Given this list of marker genes Nrp1, Notch1, Ccl28, Dmd, Cass4, Pdgfb, Grem1, Clasp1, Myf5, Dapk3, Mink1, Dusp3, Bcl6, Bcar1, Cdh13, Ppm1f, Onecut2, Plpp3, Cd36, Spry4, Col8a1, Map4k4, Bcl2, Nid1, Ecm2, Lgals1, Wdpcp, Rac2, Disc1, Enpp2, Gsk3b, Col16a1, Pkhd1, Npnt, Src, Col26a1, Rhoa, Egfl6, Unc13d, Ccl21f, Mdk, Braf, Foxf1, Ccl21b (C-C motif chemokine ligand 21B (leucine)), Nf1, Arpc2, Plg, Adam15, Spp1, Acvrl1, Smoc1, Dmp1, Plekha2, Cripto, Cdk6, Has2, Edil3, Iqgap1, Rac3, Crkl, Rhod, Smoc2, Dmtn, Gpm6b, Fzd4, Dlc1, Mmp14, Onecut1, Triobp, Ptk2b, Ptn, Ddr1, Sdc4, Macf1, Camsap3, Col1a1 (collagen, type I, alpha 1), Rcc2, Muc21, Flna, Smad3, Lims1, Kank1, Epha3, Jup, Olfm4, Dnm2, Lrp1 (low density lipoprotein receptor-related protein 1), Dock5, Clasp2, Rin2 (Ras and Rab interactor 2), Coro1c, Dag1, Nexmif, Vtn, Fn1, Coro2b, Angpt2, St6gal1, Prkce, Wnt1, Dicer1, Csf1, Tbcd, Cask, Rras, Ptprz1, Ilk, Nedd9, Serpine1, Slk, Sec1, Fut1, Thy1, Itgb3 (NCBI Gene Id 268495), Jak2, Emp2, Tek, C1qbp, Ccdc80, Itgb1bp1, Ptprj, Tsc1, Rac1, Hsd17b12, Meltf, Crk, Skap1, Mmp12, Ajap1, Alox15, Spock2, Ccl21a, Itga3, Arhgap6, Rreb1, Ap1ar, Tacstd2, S100a10, Calr, Ccl21d, P4hb, Pkp2, Fbln2, Itga5, Jag1, Gcnt2, Spock1, Rock1, Rell2, Emilin1, Fermt2, Efemp2 (epidermal growth factor-containing fibulin-like extracellular matrix protein 2), Fbln1, Fermt1, Pcsk5, Abi3bp, Ndnf, Efna5, Pten, Ptk2 (NCBI Gene Id 14083), Cib1, Thbs1, Dusp22, L1cam, Sema3e, Hoxa7, Phldb2, Fam107a, Epha1, Actg1, Cdkn2a, Pdpn, Ptpn1, Wnt4, Poldip2, Dbn1, Fmn1, Muc4, Abl1, Rsu1, Hrg, Rasa1, Ccn1, Vwc2, Utrn, Itgb1, Vit, Trem1, Peak1, Myh9, Cfl1, Myadm, Stk4, Atxn3, Gfus, Carmil1, Men1, Prex1, Tesk1, Cdc42, Acer2, Vegfa, Npy2r, Prkcz, Npy, Egflam, Apod, Ccl25, Hacd1 (3-hydroxyacyl-CoA dehydratase 1), Itga6, Plet1, Apoa1, Kdr, Myoc, Postn, Vcl, Arl2 (ADP-ribosylation factor-like 2), Plau, Cspg5 (NCBI Gene Id 29873), Fzd7, Pik3r1, Lims2, Epb41l5, Ptpn11, Ptpra, Pik3cb, Ldb1, Cd3e, Ninj1, Actn4 (actinin alpha 4), Bst1, Ccl21e, Dab2, Dock1, Agr2 (anterior gradient 2), Limch1, here is a description of the gene set: species: Mus musculus Any process that modulates the frequency, rate or extent of cell-substrate adhesion. Cell-substrate adhesion is the attachment of a cell to the underlying substrate via adhesion molecules. Mouse Gene Set: GOBP_REGULATION_OF_CELL_SUBSTRATE_ADHESION